The following is a description of a gene set: Any process that modulates the frequency, rate or extent of cilium assembly. Human Gene Set: GOBP_REGULATION_OF_CILIUM_ASSEMBLY species: Homo sapiens, and this is the list of marker genes: RAB11A, TBC1D13, LUZP1, DZIP1 (DAZ interacting zinc finger protein 1), DYNC2LI1, ARF4, CCDC88A, WRAP73, TBC1D1, MNS1, BBS4, SDCCAG8, KIF24, ATG5, TAPT1, RABEP2, TBC1D8, GDI2, AKT1, CYLD, ARHGAP35, TBC1D10C, TBC1D5, TBC1D10A, TBC1D2, ZMYND10, ODF2, EVI5, HAP1, TBC1D10B, ADAMTS16, YAP1, TBC1D20, SAXO1, IFT88, TBC1D7, ENTR1, RP1, MCIDAS, CROCC, TBC1D22B, TCHP, TBC1D21, IFT140, ATG3, WDR44, EVI5L, TBC1D30, ODAD3, MAPK15, WDPCP, CDK10, TTBK2 (tau tubulin kinase 2), LIMK2, TBC1D17, TBC1D9B, SEPTIN9, IFT20, TBC1D14, ODF2L, KCTD17, USP6NL, HTT, TRIM32, TBC1D2B, TBC1D19, SGSM3, MPHOSPH9, DCDC2, RABGAP1, LIMA1, FUZ, TBC1D22A, TBC1D15, TESK1, CCP110, TBC1D3, TBC1D24, CDKL1, SEPTIN7, CEP120, CEP135, PPP1R35, DYNLT2B, CNTROB, ATMIN, RAB11FIP3, CENPJ, CDKL5, MARK4, MAK, NOTO, TBC1D16, MAP4, MARCHF7, GSK3B, SYNE2, CEP97, INTU, LPAR1